The following is a description of a gene set: Any process that activates or increases the frequency, rate, or extent of production of transforming growth factor-beta. Human Gene Set: GOBP_POSITIVE_REGULATION_OF_TRANSFORMING_GROWTH_FACTOR_BETA_PRODUCTION species: Homo sapiens, and this is the list of marker genes: FOXP3, CREB1, CX3CL1, CD46, SERPINB7, CD200, ATP6AP2, MYB, SMAD3, XCL1, PTGS2, MIR149, THBS1 (NCBI Gene Id 7057), SERPINF2, FERMT1, ATF2, BMPR1A, WNT11, LUM, LGALS9